The following is a description of a gene set: Human Gene Set: GSE26030_TH1_VS_TH17_DAY5_POST_POLARIZATION_UP Serial comparison between Th1 and Th17 tumor-specific cells cultured in vitro and ex vivo after transferred into sublethaly irradiated B6.PL mice. Th17-derived cells acquire Th1-like properties in vivo but maintain a distinct molecular profile. from publication Muranski P, Borman ZA, Kerkar SP, Klebanoff CA, Ji Y, Sanchez-Perez L, Sukumar M, Reger RN, Yu Z, Kern SJ, Roychoudhuri R, Ferreyra GA, Shen W, Durum SK, Feigenbaum L, Palmer DC, Antony PA, Chan CC, Laurence A, Danner RL, Gattinoni L, Restifo NP (PMID 22177921) Genes up-regulated in T helper cells 5 days post polarization: Th1 versus Th17. species: Homo sapiens, and this is the list of marker genes: ATP12A, AGRN, MED12L, SAMD9L, TMEM106A, IRF9, ISG15, HMOX2, HMGN3, INPP1, EVI2A, DNMT3L, DDX60, OASL (NCBI Gene Id 8638), CA13, DAXX, IRF7, EIF5B, NAMPT, NOC3L, ZBP1, GHR, CFAP210, HAP1, IFI44L, CD86, UBR4, STAT1, POLR3E, HOXD4, IL15, NLRC5, SFXN2, CACNA1A, FAM111A, LARS1, FCF1, RSAD2, STAT2, DTX4, VTA1, TRIM5, DNASE1L3, KRT15, TNFSF10, ISG20, IFITM3, IFI27L2, HSH2D, CKM, BYSL, NIF3L1, UBALD2, NSUN2 (NCBI Gene Id 54888), HLA-E, IFIT1B, MPEG1, GRAMD2B, UTP6, CSF1, TLR3, EIF2AK2, NIT2, ZNF365, RUVBL1, DHX58, NMI, COX18, PRRG4, SYTL1, TKTL1, GBP6, CXCL10, PITX1, EYA3, SLC15A3, PARP9, GPR65, CUTC, LBX2, GHITM, HOOK2, KEAP1, IFIT2, LGALS3BP, EPRS1, EHD3, ZCCHC18, NVL, KATNA1, IL12RB1 (NCBI Gene Id 3594), TUBA8, SLFN12L, POLR3B, TPST1, AKAP3, PARP12, PDE7B, EPSTI1, TENT4A, SYCE1L, CHMP4B, C7orf50, IFIT1, RNF114, GBP7, SGCB, OAS2, NAA20, ZUP1, ADSS2 (NCBI Gene Id 159), SLFN5, NT5C3A, HSPA5, RRP15, SLFN13, USP18, CYP2B6, PARP14, XAF1, SH2D4B, OAS1, DPP4, BST2, ZCCHC2, MARCHF5, TMA16, NR1H3, SLC6A17, PFKFB3, HELZ2, LRFN3 (leucine rich repeat and fibronectin type III domain containing 3), IFI44, HERC6, ST3GAL6, NOTCH1, IFIT3, CGAS, SSBP4, GBP2, PML, VCPKMT, PPA1, TDRD7, SAMHD1, IRGM, TLX1, NSUN4, PARP11, CARMIL1, MITD1, MSGN1, TLR7, CMPK2, MX1, TNKS1BP1, GTF2F2, DOP1B, CAPN5, RTP4, CRCP, TOR3A, PNO1, AMIGO2 (adhesion molecule with Ig like domain 2), LARP1, RNF213, SETDB2, COL9A3, HLA-C, MCOLN3, LAP3, TOR1AIP2, MGST2, SIDT1, SLC25A12, RILPL1, CHIC1, CD47, TMEM140, GYPC, CCRL2, SEBOX, MX2, MRPL39, NXPE2, C19orf12, TRIM21, TRAFD1, PKIB, DTX3L, IFI35, DLL1, NMRAL1, OAS3, IFIH1, PLAC8, MAX, CD69, HCK, AMHR2